The following is a description of a gene set: part of: Intestinal absorption Hexoses, notably fructose, glucose, and galactose generated in the lumen of the small intestine by breakdown of dietary carbohydrate, are taken up by enterocytes lining the microvilli of the small intestine and released from them into the blood. Uptake into enterocytes is mediated by two transporters localized on the luminal surfaces of the cells. SLC5A1, also known as SGLT1, mediates the co-transport of sodium ions and glucose and galactose, and SLC2A5, also known as GLUT5, mediates fructose uptake. Tetrameric SLC2A2, also known as GLUT2, localized on the basolateral surfaces of enterocytes, mediates the release of these hexoses into the blood (Kellett & Brot-Laroche 2005; Wright et al. 2004). Reactome Pathway: Intestinal hexose absorption species: Homo sapiens, and this is the list of marker genes: RSC1A1, SLC5A1, SLC2A2, SLC2A5